Given this list of marker genes TIMP2, MMP10, PRSS1, CTSK, MMP11, COL18A1, KLKB1, MMP3, PLG, CTSG, MMP1, MMP8, PRSS2, MMP9, MMP7, MMP24, MMP15, CTRB1, SPOCK3, FURIN, ELANE, CMA1, MMP14, MMP13, MMP17, MMP2 (matrix metallopeptidase 2), MMP25, TPSAB1, CTRB2, TIMP1, KLK2, CTSV, MMP16, here is a description of the gene set: The matrix metalloproteinases (MMPs), previously known as matrixins, are classically known to be involved in the turnover of extracellular matrix (ECM) components. However, recent high throughput proteomics analyses have revealed that ~80% of MMP substrates are non-ECM proteins including cytokines, growth factor binding protiens, and receptors. It is now clear that MMPs regulate ECM turnover not only by cleaving ECM components, but also by the regulation of cell signalling, and that some MMPs are beneficial and may be drug anti-targets. Thus, MMPs have important roles in many processes including embryo development, morphogenesis, tissue homeostasis and remodeling. They are implicated in several diseases such as arthritis, periodontitis, glomerulonephritis, atherosclerosis, tissue ulceration, and cancer cell invasion and metastasis. All MMPs are synthesized as preproenzymes. Alternate splice forms are known, leading to nuclear localization of select MMPs. Most are secreted from the cell, or in the case of membrane type (MT) MMPs become plasma membrane associated, as inactive proenzymes. Their subsequent activation is a key regulatory step, with requirements specific to MMP subtype. Reactome Pathway: Activation of Matrix Metalloproteinases species: Homo sapiens part of: Degradation of the extracellular matrix